Given this list of marker genes Tmem127, Cdc23, Antxr2, Zbtb10, Acad8, Impg1, Plxnc1, Rab5if, Tef, Hipk1, Serpinb9g, Otub2, Nell1, Garre1, Tacc1, Rab5a, Lmbr1, Ptprt (NCBI Gene Id 19281), Lce1j, Zfp426, Ghitm, Hdac9, Csta1, Fech, Zmat4, Gstm2, Ubl3, Creg1, Zfp420, Ank1, Slc38a8, Tubgcp6, Kcnc3, Acss2, Gucy1a1, Wdfy3, Eif4b, Cab39l, Hbq1b, Tmc7, Sema4g, Lzts3, Sorcs2, 1700020L24Rik, Fam163a, Rab8b (RAB8B, member RAS oncogene family), Rpia, Gckr, Stc2 (NCBI Gene Id 20857), Xk, E130308A19Rik, Mcrs1, Camk1d, Hapln1, Bace1, Rest, Zfp282, Paip2b, Upk1b, Bach1, Tom1l2, Stag2, Dach2, 5730507C01Rik, Cxcl16, Sema6a, Zfp120, Btbd9, Foxj2, St8sia3, 1700071K01Rik, Steep1, Cysltr2, Ces2e, Ino80d, Zfp1008, Rap1gds1, Tbc1d12, Arid3b, here is a description of the gene set: species: Mus musculus from publication Chen Y, Wang X (PMID 31504780) Mouse Gene Set: MIR_6397 Genes predicted to be targets of miRBase v22 microRNA mmu_miR_6397 in miRDB v6.0 with MirTarget v4 prediction scores > 80 (high confidence targets).